Given this list of marker genes Taldo1, Aqp7, Hk2, G0s2, Acsl1, Entpd5, Cfd, Uck1, Adipoq, Apoc4, Rnf11 (ring finger protein 11), Hsd17b4, Rasd1, Fasn, Dgat1, Ech1, Cidec, Pparg, Scarb1, Gpam, Aldh1a7, Lpl, Idh1, Sorbs1, Aoc3, Orm1, Selenbp1, Col15a1, Tob1, Ltc4s, Abcd2 (NCBI Gene Id 26874), Acadm, Qki, Cebpa, Me1, Slc2a4, Tst, Reep5, Cdkn2c, Plin4, Fxyd1, Acox1, Ak2, Cib2, Tpp2 (tripeptidyl peptidase II), Pla2g6, Acads, Nr1h3, Pfkfb1, Pck1, Cebpg, Itga6, Retn, Rgs2 (NCBI Gene Id 19735), Arl4a, Hipk2, Pxmp2, Ap3s1, Esyt1, Adrb3, Cbx4, Pex11a, Mmut, Nrip1 (NCBI Gene Id 77882), Bckdha, Pcx, Idh3g, Alad, Nnmt, Alas1, Nfs1, Irx3, Dbi, Lama4, Aatk (apoptosis-associated tyrosine kinase), Hipk3, Dhrs3, Gpd1, Fabp5, here is a description of the gene set: Mouse Gene Set: RUAN_RESPONSE_TO_TNF_DN Troglitazone (TGZ), a member of the thiazolidinedione class of anti-diabetic compounds and a peroxisome proliferator activator receptor-gamma (PPAR-gamma) agonist, restores systemic insulin sensitivity and improves the full insulin resistance syndrome in vivo. The mechanisms underlying its in vivo function are not understood. Here we investigated the potential functional interaction between PPAR-gamma and NF-kappaB in adipocytes. We show that TGZ selectively blocked tumor necrosis factor-alpha-induced and NF-kappaB-dependent repression of multiple adipocyte-specific genes and induction of growth phase and other genes. This occurs without interfering with NF-kappaB expression, activation, nuclear translocation, or DNA binding and without suppressing NF-kappaB-dependent survival signals. Notably, the expressions of some tumor necrosis factor-alpha-induced genes in adipocytes were unaffected by PPAR-gamma activation. In reporter gene assays in HeLa cells, ectopic expression of PPAR-gamma abolished induction of a NF-kappaB-responsive reporter gene by the p65 subunit (RelA) of NF-kappaB, and the inhibition was further enhanced in the presence of TGZ. Conversely, overexpression of p65 inhibited induction of a PPAR-gamma-responsive reporter gene by activated PPAR-gamma in a dose-dependent manner. The inhibitory effect was independent of the presence of NF-kappaB-binding sites in the promoter region. Other NF-kappaB family members, p50 and c-Rel as well as the S276A mutant of p65, blocked PPAR-gamma-mediated gene transcription less effectively. Thus, p65 antagonizes the transcriptional regulatory activity of PPAR-gamma in adipocytes, and PPAR-gamma activation can at least partially override the inhibitory effects of p65 on the expression of key adipocyte genes. Our data suggest that inhibition of NF-kappaB activity is a mechanism by which PPAR-gamma agonists improve insulin sensitivity in vivo and that adipocyte NF-kappaB is a potential therapeutic target for obesity-linked type 2 diabetes. Adipocyte abundant genes down-regulated in 3T3-L1 cells (fibroblasts induced to differentiate to adipocytes) in response to TNF. from publication Ruan H, Pownall HJ, Lodish HF (PMID 12732648) studied in species Mus musculus